Given this list of marker genes Fto, Slc7a10, Fndc5, Fbn1, Sirt1 (NCBI Gene Id 93759), Ptgs2, Tfe3, Six1, Rreb1 (ras responsive element binding protein 1), Gata2, Napepld, Hnrnpu, Sox13, Mecom, Lep, Vstm2a, Dusp10, Mtor, Trpv4, Prdm16 (NCBI Gene Id 70673), Flcn, Ffar4, Bmp7, Metrnl, Mapk14, Pim1, Zbtb7b, here is a description of the gene set: Mouse Gene Set: GOBP_REGULATION_OF_BROWN_FAT_CELL_DIFFERENTIATION studied in species Mus musculus Any process that modulates the rate, frequency, or extent of brown fat cell differentiation. Brown fat cell differentiation is the process in which a relatively unspecialized cell acquires specialized features of a brown adipocyte, an animal connective tissue cell involved in adaptive thermogenesis. Brown adipocytes contain multiple small droplets of triglycerides and a high number of mitochondria.